Given this list of marker genes KDELR2 (NCBI Gene Id 11014), MAPK1, FRAT2, PBX3 (PBX homeobox 3), AP3D1, H1-4, ZFAND3, ZNF408, RAMP1, RMND5A, ID3, CCDC198, ZNF223, SIGLEC9, RSBN1, FLCN, PIK3R5, PNMA1, TSC22D3, PPAT, MFAP3, TCF20, SASH3, GABARAP (NCBI Gene Id 201246), ABCF2, PLEKHJ1, TSSK1B, CRY1, MTMR14, TIMM17B, PI4KB, CETN3, WDR19, PYGB, PTPN9, ZFP37, TSEN2, ADGRF1, PIK3IP1, LBX1, ACVR1B (activin A receptor type 1B), POLR2B, PGM1, VAMP3, SHMT1, NTRK1, IMPA2, RMND1, S100A11, BCAT2, CDK19, NME7, MORC2, RNF114, RNPEPL1, SNRK, FARP2, ZNF573, ABHD6, PYY, ABCD3, CHFR, FGGY, ATG12, NCOA4, GAS7, DNAAF2, ENG, RDH11, UQCRH, HCFC1, ESYT1, XPOT, S1PR5, AP1S2, CAMK4, DCLRE1B, PEX6, UGDH, TRH, HTRA2, TRIM8, RPP14, CLPP, MCCC1, CRIPT, NCOR1, PPM1F, RPL22, AKR1C4, MNT, MEAF6, GBF1, RREB1, DYNLL1, ACTG1, TMC6, LUC7L3, MKRN2, POLR3C, COIL, RIN3, TBCC, ATP6V1C1, MMS19, NAALAD2, AMZ2, FGR, AKAP1, TFDP1, PFDN4, ACBD4, VCAN, CDC34, RBM4B, APPL2, CRYL1, SLC30A1, CEBPA, ARL6IP5, CYC1, SNAPC5, MXI1, PTTG1IP, ZNF142, ATIC, CELF2, MIOS, TNFSF8, PIP4K2B, DKC1, BEND5, PRDX3, CEP68 (NCBI Gene Id 23177), ATP5F1E, POLR2C, TDG, DEFB126, ANP32B, FSCN1, NSF (NCBI Gene Id 4905), COMMD9, SPAST, RPL35A, DYNC1LI1, BICD2, LSM14A, TXNDC9 (thioredoxin domain containing 9), TLE3 (TLE family member 3, transcriptional corepressor), FAHD2A, NDUFAB1, GAPDH, NACC2, LRRK1, GDE1, ELAVL1, MERTK, TRIP4, MDN1, FTL, RAB6A, EDC4, DPEP3, SWAP70, ABCA5, VAMP1 (vesicle associated membrane protein 1), PAPOLG, SDHAF1, LCK, GATD3, FDFT1, LBR, FASTK, PAPOLA, GDI2, GABARAPL1, ATP6V0B, MRFAP1L1, VPS37C, RASSF1, ZCCHC8, RALBP1, ADIPOR1, PLAG1, MRPL49, OSBPL11, MKNK1, CEMIP2, RPL13P5, GGA2, CBR4, FBXO9, FRAT1, MAVS, MARCHF1, FAM131A, C1orf50, PIP4K2C (NCBI Gene Id 79837), ZNF268, here is a description of the gene set: from publication Querec TD, Akondy RS, Lee EK, Cao W, Nakaya HI, Teuwen D, Pirani A, Gernert K, Deng J, Marzolf B, Kennedy K, Wu H, Bennouna S, Oluoch H, Miller J, Vencio RZ, Mulligan M, Aderem A, Ahmed R, Pulendran B (PMID 19029902) The immune responses generated by YF-17D by profiling genes in PBMCs from 2 donors cultured with YF-17D vaccine were accessed after 3 and 12 hours. studied in species Homo sapiens Human Gene Set: GSE13484_3H_UNSTIM_VS_YF17D_VACCINE_STIM_PBMC_UP Genes up-regulated in comparison of unstimulated peripheral blood mononuclear cells (PBMC) cultured for 3 h versus PBMC cultured for 3 h with YF17D vaccine.